The following is a description of a gene set: studied in species Homo sapiens Th1 and Th2 cells arise from a common precursor cell in response to triggering through the TCR and cytokine receptors for IL-12 or IL-4. This leads to activation of complex signaling pathways, which are not known in detail. Disturbances in the balance between type 1 and type 2 responses can lead to certain immune-mediated diseases. Thus, it is important to understand how Th1 and Th2 cells are generated. To clarify the mechanisms as to how IL-12 and IL-4 induce Th1 and Th2 differentiation and how TGF-beta can inhibit this process, we have used oligonucleotide arrays to examine the early polarization of Th1 and Th2 cells in the presence and absence of TGF-beta after 0, 2, 6 and 48 hours of polarization. from publication Lund R, Aittokallio T, Nevalainen O, Lahesmaa R (PMID 14607935) Genes down-regulated in CD4 T cells activated by anti-CD3 and anti-CD28: TGFB1 and IL4 (6h) versus IL-12 (6h). Human Gene Set: GSE2770_TGFB_AND_IL4_VS_IL12_TREATED_ACT_CD4_TCELL_6H_DN, and this is the list of marker genes: CHML, EIF3B, GATC, RUFY3, UBE2E2, GNAQ, FOXO3, MKRN2, DPH6, HIRIP3, DLAT, TRIM32, CRYBG1, MRPL40, MMACHC, NUDT19, SPRYD7, TMEM209, DDT, HARBI1, RDH11, ATF6 (NCBI Gene Id 22926), NDUFC2 (NADH:ubiquinone oxidoreductase subunit C2), RPP25, DCTPP1, SEPTIN11, RPL22, ASCC2, SETD7, KNOP1, UBAC2, BCAP29, ZBTB44, CASP2, TMEM68, TALDO1, NUDT5, AK4, SLC35F2, POLDIP2, SH3RF1, SLC25A15, CCDC116, KLF16, POLR2I, KPNA2, PDS5B, PKM, SLC39A11, MAGOHB, GNPAT, MRPL15, RMND5A, GLMN, ATP5PF, DPP3, TRMT5, RPL3, CPOX, TRUB1, GSE1, PFDN4, CCDC107, PHF10, ECD, SLC19A2, ZNF771, SAMD1, DUSP12, FTX, MRPS21, PPARGC1B, COASY, PRDX2, C6orf89, TANC2, SUPT3H, SPTSSA, LIPT1, CDK2AP1, PGLS, UQCC6 (ubiquinol-cytochrome c reductase complex assembly factor 6), PYCR3, CDC14B, CCT4, ZNF428, CEBPG, PTP4A3, SSBP1, TDP1 (tyrosyl-DNA phosphodiesterase 1), SNHG3, SIL1, C7orf25, AFP (NCBI Gene Id 174), IPO11, XPC, GPR68, HLCS, ATF6B, FAM89B, RREB1, BICDL1, SAC3D1, DGAT2, AKT1S1, CA12 (carbonic anhydrase 12), GRAMD1B, NDUFAF6, HRAS, DHX35, TUBA3C (tubulin alpha 3c), ADH5, MRPL38, SAE1, PECR, L2HGDH, GCSH, GCAT, SAP30, DNAJC11, HNRNPA0, TSEN54, ZBTB26, TAF4, FADS6, PTAR1, PGM3, KTN1, ACP1, MSL3, UBE2E3, STX11, ZMYM1, N4BP2, FBXO45, NDOR1, FABP5, TMEM238, DPAGT1, TTC4, ACY1, ISYNA1 (inositol-3-phosphate synthase 1), RPL24, MID1IP1, GRHL1, ASNS, TUBB6, SOAT2, TTLL12, BMI1, IL1RAP, ZNF511, EGLN3, GFER, EXOC4, MLF2, METTL2B (NCBI Gene Id 96672), CDC23, MTA1, NUP205, LRP8, IARS2 (isoleucyl-tRNA synthetase 2, mitochondrial), TBPL1, TRIP13, THOC7, UTP20, SIGMAR1, HYPK, KLF11, CDIN1, DUSP5, PRDX3, CDC26, XXYLT1, CARNMT1, ATP5MC2, CCDC6, MDC1, B3GNT2, SAV1, HPF1, UQCRQ, PLXND1, SND1, USP10, CLIC4, IL21, CENPV, MEMO1, LONRF1, DBP, GTF2H2 (NCBI Gene Id 2966), NHP2, NDUFA13, ACOT7, NETO2, MESD, RNF11, HACD2